The following is a description of a gene set: from publication Hay SB, Ferchen K, Chetal K, Grimes HL, Salomonis N (PMID 30243574) species: Homo sapiens Human Gene Set: HAY_BONE_MARROW_NAIVE_T_CELL, and this is the list of marker genes: RPS14, BTG2, PRMT2, SSR2, NSG1, PCSK1N, EML4, THEMIS, PLK3, DYNLT3, RPL14, RPL22, LINC02273, EIF1, ANXA2R, PIM2, CMPK1, SARAF, SIRPG, ITPKB-AS1, ACSL6, CLEC2D, SLFN5, SFI1, TSHZ2, MHENCR (melanoma highly expressed competing endogenous lncRNA for miR-425 and miR-489), USP36, TNRC6B, ITK (NCBI Gene Id 3702), RPL29, KLF2, TNIK, RPL36, SNHG32, CD28, RPS26, CRIP2, TRABD2A, GALT, LINC02361, PTGER4, MORC2-AS1, ANKRD44, LAT, SNRPN, RNF125, C19orf53, LINC01550, PRKCH-AS1, SOCS1, RPS20, INPP4B, SHISAL2A, CCDC57, LTB, LINC00402 (long intergenic non-protein coding RNA 402), RPL27A, FAU, G3BP2, TNFRSF25, NDFIP1, RPL24, ZNF101, MAML2, ARID5B, ENSG00000271858, RPL12, ADTRP, BIN1, TMEM123, CHMP7, ICOS, ZEB1, RPS3, IL7R, FAM241B, TTC19, GCC2, RPL6, FBXO32, CD2, SFXN1 (NCBI Gene Id 94081), RPL21, WNT7A, MPZL3, MALAT1, LBH, RPL18, BLOC1S4, CD40LG, TTC39C-AS1, KRT73-AS1, TRADD, RPL5, TNFAIP8, CD3D, TRBC2, NELL2, CPA5, RPS29, VAMP2, ICAM3, TC2N, RPS19, PAG1, EPHA1-AS1, SNRPD2, GPSM3, TRAT1, EIF3H, MDS2, MGAT4A, RPL36AL (NCBI Gene Id 93632), TOB1 (NCBI Gene Id 10140), REG4, OCIAD2, RPL37, JUNB, B3GAT2, ZBTB25, NEFL, ENSG00000251661, MTERF4, LINC01089 (NCBI Gene Id 338799), ZC3H12D, AAK1, FAM177A1, LDHB, RPL38, ODF2L, RPS18, FOXP1, PDE3B, EIF3E, RPS7, CUTALP, RHBDD2, ARID5A, LINC02762, TESPA1, SCML4, RAB33B-AS1, PNRC1, RCAN3, USP10, BEX5, SPOCK2, RPS10, PRKCA, FAM107B, GIMAP1, CD5, HAPLN3, RPL4, GRAMD1A, RPL35A (ribosomal protein L35a), RPL32, PLEKHB1, IL23A, PIK3IP1, ARHGEF1, CNN2, TCF7, RPS12, AQP3, TMC6, PBXIP1, LSR, GPR171, LDLRAP1, CD27, ZFP36L2, SMCHD1, RPS23, RNF157, PARP11-AS1, RPL19, LEF1, TRAF1, CHD3, TRBC1, ANKRD44-AS1, RPSA, RPL13A, CDC42SE2, FLT3LG, GIMAP7, LINC00513, GALM, UBASH3A, P2RY10, MAL (mal, T cell differentiation protein), DPP4, PIK3R1, RPL39, RPS21, LEPROTL1 (leptin receptor overlapping transcript like 1), CYTH1, EPHX2, RASA3, NSMCE3, RPS17, EEF1D, RPL27, ORMDL3, SELENOK, BTG1, SEPTIN9, FXYD5, AP3M2, SEPTIN1, TRAF3IP3, RPLP2, RPS6, NMRK1, RPL31, ACAP1, PCED1B, LYPD3, GSTK1, FBLN5, SVIP, ABLIM1, RPS5, BICDL1, ETS1, P2RY8, ITM2A, RPL9, RPL13 (ribosomal protein L13), RPS28, APBA2, ANAPC16, ANO9, EVL, ARHGAP45, SUSD3, NSD3, RPL30, STMN3, RPL36A, RPS27A, ITPKB, CCR6, ANKRD12, RPL10, TMC8, VSIG1, RGL4, RPS13, RPS27, SLC38A1, CD3G, TECR, CDKN1B, CREM, TSC22D3, LINC-PINT, CORO1B, THEM4, HELB, GCNT4, TBC1D4, FXYD7, RIPOR2, PABPC1, LRRN3, TCEA3, SIT1, TUT4 (NCBI Gene Id 23318), TMEM63A (transmembrane protein 63A), MTFP1, COMMD6, OXNAD1, MPHOSPH8, RPS3A, ST3GAL1 (ST3 beta-galactoside alpha-2,3-sialyltransferase 1), STK4, GIMAP4, ADD3, GATA3, CCSER2, RPS4X, NMT2, N4BP2L2, EEIG1, LCK, SEPTIN6, U2AF1L4, PHLDB3, PATJ, FBLN7, RPL35, TPT1, CD96, RBL2, LINS1, IL2RA, SH3YL1, LACTB2-AS1, DNAJB1, CAMK4, TTC39C, RPL23A, NIPAL3, NOP53, TSTD1, EEF1A1, TSPYL2 (TSPY like 2), SERINC5, ISG20, TLE5, RGCC, AKTIP, RPL28, SNHG8, C9orf78, RPL3, DDX24, RPL17, TMEM204, SLC9A3-OT1, TOMM7, HIPK1-AS1, FYB1, ANK3, RPS25, PBX4, RPL11, RPS2, RPL10A, APBB1, EEF1B2, IL4R, ZNF331, IL16, SH2D3A, RPS15A, DHCR7-DT, SLC25A45, ATP6V0E2, RPL7, ATM, SC5D, BCL2, EIF4A2, RPS16, IL27RA, HECW2-AS1, MOAP1, ZC3HAV1, GPR82, COX7C, LINC02446, CD48, CYLD, CFAP36, KRT1, DUSP16, DGKA, CD3E, SBDS, RASGRP1, CNOT6L, YPEL5, CARS1, SRSF8, CRBN, CD69, PHF1, PASK, PPP1R2, NBEAL1, RPS15, ARHGAP15, RPL34 (NCBI Gene Id 6164), TNFRSF4, NOSIP (NCBI Gene Id 51070), RHOH, SATB1, SFMBT1, ELF1, LINC00861, RORA, CHRM3-AS2, TNFAIP3, SMDT1 (single-pass membrane protein with aspartate rich tail 1), SUPT3H, RPL18A, BCL11B, FNBP1, RPL41, EIF4B, TRAC, STAT3, DCTN6-DT, SEC14L2, CCR7, RESF1 (retroelement silencing factor 1), CD6, SF1, RIC3, RPS8, MCUB